The following is a description of a gene set: Lissencephaly gene (LIS1) in neuronal migration and development studied in species Homo sapiens Human Gene Set: PID_LIS1_PATHWAY from publication Schaefer CF, Anthony K, Krupa S, Buchoff J, Day M, Hannay T, Buetow KH (PMID 18832364), and this is the list of marker genes: DYNC1H1, PAFAH1B3, LRP8, PAFAH1B1, IQGAP1, PPP2R5D, CDK5, PAFAH1B2, NDEL1, CDC42, CSNK2A1, DCX, PLA2G7, MAP1B, ABL1, VLDLR, KATNA1, NUDC, RHOA, LRPAP1, CDK5R2, RELN, RAC1, YWHAE, CLIP1, DYNLT1, CDK5R1, DAB1